Given this list of marker genes IKBKG, GTF2E2 (NCBI Gene Id 2961), CTSK, GJA1, LPAR6, EFNB1, TARS1, FERMT1, MSX1, DKC1, TINF2, AQP5, WNT5A, ERCC3, CARS1, RNF113A, EDARADD, GTF2H5, ATR, EDAR, TERC, DVL3, FZD2 (frizzled class receptor 2), WNT10A, MPLKIP, ERCC2, ATP2A2, AARS1, SLC39A4, PORCN, KRT14, LMX1B, TERT, FOXN1, DVL1, here is a description of the gene set: Ridged nail Human Gene Set: HP_RIDGED_NAIL Longitudinal, linear prominences in the nail plate. studied in species Homo sapiens